Given this list of marker genes DCDC1, ZFYVE26, AURKB, CALM2, PDXP, NUP62, MRGPRX2, BBS4, MAP10, E2F7, PRKCE, KIF23, GIT1, KIF20A, PRC1, CHMP3, GIPC1, PLK1, EXOC7, KIF14, PIK3R4, RAB11A, PKP4, OR1A2, DRD2, SPAST, SVIL, CETN2, UVRAG, PIK3C3, INCENP, E2F8, TEX14, AHCTF1, CUL3, WNK1, CDC14C, ECT2, MAP9, KLHL13, CDCA8, KIF13A, BCL2L1, PIN1, MYO19, KLHL9, BIRC5 (NCBI Gene Id 332, baculoviral IAP repeat containing 5), TAS1R2, CHMP4C, CDC42, ANKRD53, RXFP3, CDC6, CCDC66, PRPF40A, CIT, SH3GLB1, BIRC6, KIF3B, DRD3, POLDIP2, SETD2 (NCBI Gene Id 84184), RACGAP1, BRCA2, CENPV, AURKC, CALM3, SSTR5, CDC14B, OR2A4, RAB11FIP4, CXCR5, KLHL21, ENTR1, FSD1, OPN1MW2, PLK3, CSPP1, RAB11FIP3, RHOA, CCP110, BECN1, ATXN10, ZFYVE19, PKN2, ARF6, CDC25B, TAS2R13, CDC14A, KIF20B, OPN1LW (NCBI Gene Id 8261), AURKA, OPN1MW, VPS4A (NCBI Gene Id 27183), CALM1, here is a description of the gene set: species: Homo sapiens Any process that modulates the frequency, rate or extent of the division of the cytoplasm of a cell and its separation into two daughter cells. Human Gene Set: GOBP_REGULATION_OF_CYTOKINESIS